Given this list of marker genes HCN2, PDE3A, TLR7 (NCBI Gene Id 51284), PDE2A, HCN4 (hyperpolarization activated cyclic nucleotide gated potassium channel 4), RAPGEF2, SLC6A4, NPR2, REN (renin), here is a description of the gene set: studied in species Homo sapiens Any process that results in a change in state or activity of a cell or an organism (in terms of movement, secretion, enzyme production, gene expression, etc.) as a result of a cGMP (cyclic GMP, guanosine 3',5'-cyclophosphate) stimulus. Human Gene Set: GOBP_RESPONSE_TO_CGMP